The following is a description of a gene set: Mouse Gene Set: GOBP_EMBRYONIC_SKELETAL_SYSTEM_MORPHOGENESIS studied in species Mus musculus The process in which the anatomical structures of the skeleton are generated and organized during the embryonic phase., and this is the list of marker genes: Smad3, Hoxd4, Hoxd10, Mmp14, Col11a1, Dlg1, Alx1, Shox2, Alx3, Six4, Hoxa2, Hoxb9, Fgfr2, Tgfbr2, Prrx2 (paired related homeobox 2), Hoxb5 (NCBI Gene Id 15413), Pdgfra, Hoxa9, Megf8, Eif4a3l1, Hoxa5, Fuz, Mycn, Six1, Slc39a1, Tgfbr1, Myf5, Setd2, Hoxb3, Hoxb2, Dync2i1, Mdfi, Gsc, Ndst1, Dscaml1, Pds5a, Asxl2 (NCBI Gene Id 75302), Smad2, Dlx2, Pax5, Axin1, Tgfb3, Zeb1, Irx5, Wnt9a, Nodal (nodal growth differentiation factor), Hoxa7, Med12, Gnas, Six2, Hoxc11, Hoxb8, Wdr19, Wnt9b, Eya1, Grhl2, Hoxb6, Men1, Rdh10 (NCBI Gene Id 98711), Runx2, Flvcr1, Osr2, Hoxd9, Ift140, Gas1 (growth arrest specific 1), Pcgf2, Hspg2 (NCBI Gene Id 15530), Col2a1, Twist2, Nog, Satb2, Dlx1as, Chst11, Hyal1, Lhx1, Hoxa11, Bmi1, Hoxa3, Hoxa4, Hoxb7, Sox11, 2610005L07Rik, Ext1, Fgf8, Osr1 (odd-skipped related transcription factor 1), Hoxb4 (homeobox B4), Tgfb2, Tbx1, Hoxd11, Hoxb1, Slc39a3, Hoxc9, Hoxc4, Foxc2, Eif4a3l2, Alx4, Twist1, Bmp4, Tfap2a, Eif4a3, Mmp16, Ctnnb1, Gli3 (GLI-Kruppel family member GLI3), Mef2c, Hoxd3, Prrx1, Hoxa1, Tulp3, Mthfd1l, Bmp7, Nipbl, Tbx15